Given this list of marker genes PIP4K2A, MTMR6, PLCB3, INPP5D, INPP5E, PLCB2, PIKFYVE, PLCB4, PLCE1, INPP4A, TPTE2, MTMR1, MTMR2, MTM1, MTMR8, SACM1L, PLCD3, PIP5K1B, INPP5K, PIK3C2G, PLCG1, PLCD1, FIG4, INPP4B, PIP4P1, PIP4K2C, PIK3C2B, PI4KA, PI4K2A, PI4KB, PIP4K2B (NCBI Gene Id 8396), PI4K2B, PIP5K1A, PIK3CG, PTEN, PIK3CD, PLCD4, PIK3CA, IPMK, PLCG2, PIK3CB, PIK3C2A, PLCB1, PIP4P2, OCRL, PIP5K1C, here is a description of the gene set: Human Gene Set: WP_PHOSPHATIDYL_INOSITOL_PHOSPHATE_PATHWAY species: Homo sapiens Phosphatidyl inositol phosphate pathway